The following is a description of a gene set: studied in species Homo sapiens Cholesterol metabolism Human Gene Set: WP_CHOLESTEROL_METABOLISM, and this is the list of marker genes: APOE, FABP2, CD36, LRP1, SQLE, ANGPTL3, SAR1B, ABCA1, FDPS, STARD3, SLC27A4, NPC1L1, ACAT2, SC5D, DGAT1, LDLR, MVK, CYP27A1, SCARB1, HSD17B7, STAR, HMGCR, APOA1, NPC2, APOB, VDAC1, ABCG5, DHCR24, MYLIP, LSS, TSPO, LBR, CETP, CYP7A1, IDI1, NPC1, NSDHL, ABCB11, PCSK9, PLTP, LIPA, MTTP, APOH, APOC1, CYP51A1, ABCG8, APOA4, LCAT, FDFT1, OSBPL5, APOC2, SOAT1, MSMO1, LIPG, SORT1, LIPC, LPL, DHCR7, APOC3, ANGPTL8 (angiopoietin like 8), EBP, CIDEB, LRPAP1, LPA, HMGCS1, APOA2, MGAT1, MVD, TM7SF2, PMVK (phosphomevalonate kinase), VAPA, LDLRAP1